The following is a description of a gene set: Dynein recruitment to the kinetochore. Pathway ID: N01534. Pathway type: Reference. Pathway class: nt06515 Regulation of kinetochore-microtubule interactions. Human Gene Set: KEGG_MEDICUS_REFERENCE_DYNEIN_RECRUITMENT_TO_THE_KINETOCHORE Pathway Definition from KEGG: BUB1+CENPF == RZZ == (NDE1+NDEL1+LIS1),SPDL1,Dynactin == Dynein studied in species Homo sapiens, and this is the list of marker genes: BUB1, DCTN2, DYNLT1, DYNLRB1, DCTN5, DYNLL1, DYNLRB2, DCTN3, ACTR10, DYNC2LI1, DCTN1, DYNLT3, DCTN4, DYNC1I1, DYNC1I2, DYNC2H1, CENPF, ZW10, ACTR1A, DCTN6, SPDL1 (spindle apparatus coiled-coil protein 1), NDE1, NDEL1, KNTC1, DYNC1H1, DYNLL2, PAFAH1B1, DYNC1LI2, DYNC1LI1 (dynein cytoplasmic 1 light intermediate chain 1), ZWILCH